The following is a description of a gene set: studied in species Homo sapiens Urethral atresia Human Gene Set: HP_URETHRAL_ATRESIA Congenital anomaly characterized by closure or failure to develop an opening in the urethra., and this is the list of marker genes: TMEM231, CSPP1, RPGRIP1L, FREM2, GRIP1, B9D2, TXNDC15, CEP290, RPGRIP1, B9D1, TP63, WNT3, TMEM237, TMEM216 (transmembrane protein 216), ZIC3, TMEM107, MKS1, TMEM67, TCTN1, FANCB, TCTN3, FRAS1, TCTN2, CC2D2A